Given this list of marker genes Ezh1, Eed, Wdr5, Kat8, Ruvbl1, Kansl1, Aebp2, Phf19, Hoxb5os, Prdm8 (PR domain containing 8), Jarid2, Kmt2c, Rnf2, Max, Wdr5b, Kmt2d, Prdm4, Uty, Prmt5, Bod1, Hdac2, Pelp1, Taf4, Cxxc1, Mcrs1, Rbbp4, Rbbp5, Chaer1, Taf7, E2f6, Sirt1, Ino80c, Nsd1, Tex10, Rbbp7, Dpy30, 0610010K14Rik, Mtf2, Suz12, Cbx5, Paxip1, Ruvbl2, Kmt2b, Dnmt3l, Ncoa6, Bod1l, Setd1a, Hcfc2, Trim37, 9630013A20Rik, Taf9, Prpf31, Pagr1a, Zfp335, Ezh2, Hcfc1, Evx1os, Las1l, Chd8, Taf1, Setd1b, Epop, Wdr82, Ash2l, Dydc1, Mga, Men1, Kdm6a (NCBI Gene Id 22289), Senp3 (NCBI Gene Id 80886), Kmt2a, Phf1, Taf6 (NCBI Gene Id 21343), Hdac9, Kdm6b, Phf20 (NCBI Gene Id 228829), here is a description of the gene set: A multimeric complex that is able to catalyze the addition of methyl groups to histone proteins. species: Mus musculus Mouse Gene Set: GOCC_HISTONE_METHYLTRANSFERASE_COMPLEX